The following is a description of a gene set: Mouse Gene Set: GOBP_TOLL_LIKE_RECEPTOR_3_SIGNALING_PATHWAY species: Mus musculus The series of molecular signals initiated by a ligand binding to the endolysosomal toll-like receptor 3., and this is the list of marker genes: Oas1e, Oas1h, F2rl1 (F2R like trypsin receptor 1), Tirap, Oas1c, Tnf, Ptpn22, Trim3, Rftn1, Tnip2, Oas1b, Flot1 (NCBI Gene Id 14251), Ubqln1, Unc93b1, Oas1g (2'-5' oligoadenylate synthetase 1G), Oas1f, Peli1, Hcfc2, Tnfaip3, Cd86, Src, Tlr3, Wdfy1, Oas1a, Colec12, Havcr2, Rnf170, Ticam1, Oas1d, Irf1, Cav1, Scimp, Irf2